Given this list of marker genes KCNE5, CACNA1C, KCNE4, KCNE2, CACNB2, CACNA2D2, CACNG8 (calcium voltage-gated channel auxiliary subunit gamma 8), KCNE3, CACNG7, KCNE1, KCNQ1, CACNG4, CACNB1, AKAP9, CACNG6, here is a description of the gene set: Reactome Pathway: Phase 2 - plateau phase Phase 2 of the cardiac action potential is the plateau phase which is sustained by a balance of Ca2+ influx through L-type Ca2+ channels (LTCCs) and K+ efflux through the slow delayed rectifier K+ channel 1 (KCNQ1). This phase sustains muscle contraction (Park & Fishman 2011, Grant 2009). part of: Cardiac conduction studied in species Homo sapiens